The following is a description of a gene set: studied in species Homo sapiens IGF-IGF1R-RAS-ERK signaling pathway. Pathway ID: N00233. Pathway type: Reference. Pathway class: nt06324 GHRH-GH-IGF signaling. Pathway Definition from KEGG: IGF -> IGF1R -> GRB2 -> SOS -> RAS -> RAF -> MEK -> ERK Human Gene Set: KEGG_MEDICUS_REFERENCE_IGF_IGF1R_RAS_ERK_SIGNALING_PATHWAY, and this is the list of marker genes: GRB2, IGF2, RAF1, MAP2K2, SOS1, SOS2, HRAS, MAPK1, KRAS, IGF1R, IGF1, MAPK3, MAP2K1, NRAS, ARAF, BRAF